Given this list of marker genes HTT, SAMHD1, ADAR, TREX1, RNU7-1, PDE8B, RNASEH2C, RNASEH2A, IFIH1, RNASEH2B (NCBI Gene Id 79621), SLC2A3, LSM11, ATXN3, here is a description of the gene set: Human Gene Set: HP_DEGENERATION_OF_THE_STRIATUM studied in species Homo sapiens Degeneration of the striatum